Given this list of marker genes TAF1C, SDHC, PBDC1 (NCBI Gene Id 51260), TET2, INPP5B, ADH5, ATP8B2, MTRES1, DCBLD2, SLC5A1 (NCBI Gene Id 6523), USP5, USP21, RSPO2, SULT1A1, MED20, SNHG6, SUZ12, LZTFL1, MARVELD2, NKAPD1, LONRF2, KIF1C, MEDAG, MRPL37, BCKDK, XRCC3, GMDS, HAUS1, DHRS1, CDC20, SRR, RRS1, C16orf90, PTRH1, PDE3B, EIF5A2, ACOT8 (NCBI Gene Id 10005), IL17RC, ALOXE3, COX17, TTC9B, DGAT2, CTBS, JOSD2, NPC2, G6PC1, ATP23, HNRNPAB, NCSTN, PITHD1, RPUSD3, TESK1, DCTD (NCBI Gene Id 1635), KAZALD1, PIGX, CNDP2, ZBTB3, BMPR2, RHBDD3, CYFIP1, C2CD4B (C2 calcium dependent domain containing 4B), CEP76, EMG1, IBA57 (iron-sulfur cluster assembly factor IBA57), MND1, FBXW8, PAMR1, CNR1, EPAS1, LIPT1, SERPINH1, NSA2, PPP1R37, CCNB1IP1, FAM110B, ACD, TSPAN5, OMP, HNRNPC, CS, CD99, TRIM27, RASSF7, UNC13B, NOP9, FBLIM1, GPR27, UBR5, QRICH1, NSMCE2, UGT2B10, MRPS24 (NCBI Gene Id 64951), IL9R, NUP205, ZNHIT2, RFC5, GOSR1, SLC38A7, FOXK2, DGCR8, UTP18, NEK11, ADORA2A, SLC16A1, LMLN, AAMDC, DHRSX, PAK4, RNF4, MTR, DDX19A, FNTA, GOLGA7, NETO2, TRMT1, C3orf80, KCTD11, SNRPD2, FASTKD5, DBP, ZNF606, VCPKMT, HAS1, DDX47, DPF1, C16orf78, DANCR, NLN, JAM3, BDKRB2 (NCBI Gene Id 624), PKP4, IPO8, VMA21, XBP1, G6PD, PHC2, EED, ARHGDIA, APPL1, DNAJC13, SMARCA5, C6orf62, TAFA2, CYB5R4, TOMM7, TMEM120A, ZHX3, COMMD4, MT1E, DNAJB2, FEN1, BMP5, ERAL1, FBXL18, SCAF1, F9, DTX4, APOH, CUL2, TMEM61, MRPL27, ACOX3, AKAP4, CHTOP, ABHD11, MTDH, SCFD1, MYPOP, METTL27, EXTL2 (NCBI Gene Id 2135), FAM185A, LAG3, LBX1, LAMA5, SGCE, DPAGT1, TASP1, CUBN, ST3GAL2, FGF23, FAM133B, HK2, BST2, SSRP1, TATDN1 (NCBI Gene Id 83940), MPG, PARK7, ANKRD55, IL2RA, SPSB2, CLN3, NDUFA13, GLT8D2, MYPN, RASGEF1A, PRELID3A, PRKN, TUFM, SNHG11, ACACA, here is a description of the gene set: studied in species Homo sapiens We demonstrate that the G protein Gi3 is the cellular target of the adenosine A3 receptor (A3R). By using a cell permeable peptide comprising the C-terminal end of Gαi3 fused to an importation sequence (ALL1) as a selective inhibitor of Gi3 signaling, we show that by coupling to Gi3, the A3R stimulates multiple signaling pathways in human mast cells, leading to upregulation of cytokines, chemokines and growth factors.Following contact with activated T cell membranes, endogenous adenosine binds to and activates the A3R, resulting in Gi3-mediated signaling. Specifically, the majority of ERK1/2 signaling initiated by contact with activated T cell membranes, is mediated by Gi3, giving rise to ALL1-inhibitable cellular responses. These results unveil the physiological GPCR that couples to Gi3 and establish the important role played by this G-protein in inflammatory conditions that involve adenosine-activated mast cells. We used microarrays to detail the effect of ALL1 on gene expression of HMC-1 cells activated directly by the A3 receptor, or by contact with activated T cell membranes. from publication Baram D, Dekel O, Mekori YA, Sagi-Eisenberg R (PMID 20190146) Genes up-regulated in HMC-1 (mast leukemia) cells: stimulated with T cell membranes versus incubated with the peptide ALL1 and then stimulated with T cell membranes. Human Gene Set: GSE19888_NO_PRETREAT_VS_ADENOSINE_A3R_INHIBITOR_PRETREATED_MAST_CELL_TCELL_MEMBRANES_ACT_UP